The following is a description of a gene set: Human Gene Set: CCTGTGA_MIR513 Genes having at least one occurence of the motif CCTGTGA in their 3' untranslated region. The motif represents putative target (that is, seed match) of human mature miRNA hsa-miR-513 (v7.1 miRBase). species: Homo sapiens, and this is the list of marker genes: EI24, C1QL4, RICTOR, UGT2B15, MTUS1, RIC3, RBPMS2, NAV2, EYA1, SRGAP3, CGB2, DNM3, SH3GL3, DCUN1D4, DRD3, HNF1B, PRX, NEBL, LUC7L3, CCDC65, FGFR1, DMPK, NAT8L, CNTNAP2, TMEM260, PSMF1, YTHDF3, TBR1, SFN, TRIM71, SEMA4F, MAP4K5, PPARGC1A, CRY2, PGM2L1, RNF41, MBD6, BLCAP, RUNX1T1, GABRE, MYCBP, MPPED2, NSD2, ANTXR2, MAPK7, PRMT2, CGB1, DPYSL2, NPAS3, LRRC14, AGAP2, MTCP1, ARHGEF9, TLE4, KAT6A, SMG7, EPHB2, CYP1B1, FAM76B, PPP6R3, ELFN2, PIP4K2B, IER5, VPS35, CCDC117, QKI, ACHE, ZNF329, NTRK2, MINDY4, BNIP3L, GNAZ, PURA, RGS5, CALM3, WIPI2, EVL, TIE1, AGAP3, USP21, CA10, PSMD10, CACNA2D4, FREM1, ELAVL2, SYP, BMP8B, PPM1E, KLK15, OTUD4, ENC1, MAP3K12, KCND3 (NCBI Gene Id 3752), BTG1, CSNK1G1, CLK2, FEM1C, BAIAP2, SERTAD4 (SERTA domain containing 4), FIZ1, PPP1R16B, PDXK, CCND1, PXN, RBM4B, CLK3 (CDC like kinase 3), UBE2K, WDFY3, SNN, SZT2, CDC14B, BICRAL, RAN (NCBI Gene Id 87046), BCL2L11, OGT, DDRGK1, SRRM2, ADD3, CTNND1, GGNBP2, SARM1, SRGAP2, KAT2B, SERP1, PPP1R3B